The following is a description of a gene set: NGF-independant TRKA activation species: Homo sapiens Human Gene Set: REACTOME_NGF_INDEPENDANT_TRKA_ACTIVATION, and this is the list of marker genes: NTRK2, ADCYAP1R1, ADCYAP1, NTRK1, ADORA2A